Given this list of marker genes TICAM1, TBK1, IRF3, UNC93B1, HYOU1, NCKAP1L, CD40LG, SNORA31, DBR1, TLR3, CD27 (CD27 molecule), TRAF3, STAT1, here is a description of the gene set: species: Homo sapiens An inflammation of brain parenchyma due to infection with a virus. Viral encephalitis can occur as a rare complication of common infections (eg, herpes virus infections) or can occur as a characteristic presentation of rare viruses (eg, rabies virus infection). Encephalitis may be the only neurologic manifestation of infection, or may occur in association with meningitis, myelitis, radiculitis, or neuritis. Viral encephalitis is associated with neurological dysfunction. Human Gene Set: HP_VIRAL_ENCEPHALITIS Viral encephalitis